Given this list of marker genes SESN2, MAP3K20, PML, RBM4, DNAJC3, EIF2AK3, ANG, here is a description of the gene set: Any process that stops, prevents or reduces the rate of translation as a result of a stimulus indicating the organism is under stress. species: Homo sapiens Human Gene Set: GOBP_NEGATIVE_REGULATION_OF_TRANSLATION_IN_RESPONSE_TO_STRESS